Given this list of marker genes TLE2, HDAC1, CTBP2, AXIN2, TLE1, TLE4, TCF7, TLE5, CTBP1, TCF7L1, TCF7L2, MYC, LEF1, TLE3, here is a description of the gene set: studied in species Homo sapiens In the absence of a WNT signal, many WNT target genes are repressed by Groucho/TLE. Groucho was initially identified in Drosophila, where it has been shown to interact with a variety of proteins to repress transcription. Groucho proteins, including the 4 human homologues (transducin-like enhancer of split (TLE) 1-4), do not bind DNA directly but instead are recruited to target genes through interaction with DNA-binding transcription factors including TCF/LEF. Groucho proteins are believed to oligomerize in a manner that depends on an N-terminal glutamine-rich Q domain, and oligomerization may be important for function. Groucho/TLE proteins affect levels of gene expression by interacting with the core transcriptional machinery as well as by modfiying chromatin structure through direct interaction with histones and recruitment of histone deacetylases, among other mechanisms. In addition to the four TLE proteins, human cells also include a truncated TLE-like protein called amino-terminal enhancer of split (AES) which contains the N-terminal Q domain but lacks much of the C-terminal sequence of TLE proteins, including the WD domain which is important for many protein-protein interactions. AES is believed to act as a dominant negative, since it is able to heter-oligomerize with full-length TLE proteins to form non-functional complexes. Reactome Pathway: Repression of WNT target genes part of: Degradation of beta-catenin by the destruction complex